The following is a description of a gene set: species: Homo sapiens Germinal centers (GCs) are clusters of activated B cells built on stromal cells known as follicular dendritic cells (FDCs). In the Peyer’s patches (PPs), GCs are chronically induced by bacteria and are the major sites for generation of gut IgA immune responses. Whether FDCs directly contribute to the IgA production in PP GCs is unknown. To investigate the role FDCs in gut immune system, we examined comprehensive gene profiles of FDCs purified from PPs or perypheral lymph nodes (pLNs) with or without immunization. We also tried to reconstitute the PP FDC signature in vitro by pulsed or continuous stimulation of pLN FDCs through TLRs, RARs or simultaneously through TLRs and RARs. Human Gene Set: GSE19401_PAM2CSK4_VS_RETINOIC_ACID_AND_PAM2CSK4_STIM_FOLLICULAR_DC_UP Genes up-regulated in the in vitro follicular dendritic cells from peripheral lymph nodes (96h): Pam2CSK4 versus tretinoin and Pam2CSK4. from publication Suzuki K, Maruya M, Kawamoto S, Sitnik K, Kitamura H, Agace WW, Fagarasan S (PMID 20643338), and this is the list of marker genes: RPL36A, CYP2A7P1, AK4, MPC2, CCDC71, PPP1R10, RRAGD (NCBI Gene Id 58528), PDK2, TRIM25, CYP46A1, CYLC2, DNM1, LAX1, VWA7, POMC, PRDX1, VPREB1, GCNT4, OSTF1, KCNK10, TRIP11, DIPK1A, SELENOT, ELAVL4, MN1, DNAI1, SHC3, EEF1D, SAA3P, CMC4, NDUFB11, CANX, SUV39H1, DUSP21, NGFR, TCTN3, PTH2R, OTUB1, ASB6, FAM117A, SOS1, P3H1, PSMG2, GADD45G, ZGPAT, GAP43, ZNF669, KLHL29, OSGIN1, SLC35B1, ZFY, ZNF771, CRNKL1, CORO1C, ELL, FCER2, GATA4, FUT8, NFKBIB, MAD2L1BP (NCBI Gene Id 9587), USP2, OLR1, CHRNA6, MAGEB2, C1QA, H4C1, PPRC1, SIGLEC6, PORCN (porcupine O-acyltransferase), LINC00623, CATSPERB, GLRA1, RAB4A, VARS1, FEZ1, DYNC2I1, CSNK1G3, DDX19A, MYOZ2, CLBA1, DDX11, SLC27A3, HMGCL, C1R, DTX3, PRPSAP1, PUS7, ZNHIT3, TMED2, SLA, MGAT5, TYR, CEACAM3, KDELR2, RNF141, SLC20A2, CASP9, PTPRJ, PIGL, FBXL6, NPAS2, RASA1, CTNNA2, SPINK2, PIM2, GPN2, COPE, TDO2, ABCA1, INPP5J, DIXDC1, SLCO3A1, FKBP1A, SEC14L5, RPS10, S1PR1, SEC23IP, PSMC3, OLFML1, ASGR1, AP3S1, RBP3, ZZZ3, SLIT3, RBM23, GLI2, BRWD1, POU4F2, PNPLA6, MICAL2, HSP90AB1, CEMP1, AMFR, THNSL2, ECE2, MRPS30, RAB32, P2RY11, LBH, SH2D2A, KRT6A, PSMB4, SAFB, ANKS1B, RER1, MYBPH, RBM7, C21orf91, AATF, TRPC2, ZFPL1, NAGK, PLPP1, STAG3, KIT, GOLGA1, DLC1, HHLA2, SIRT1, SCLY, CALM3, TSPAN3, SRY, GALR1, NDUFC2, BCL11A, PLXNB1, H2BC4, KRT32, GPR27, TSSK1B, CENPM, GCNT2, LHX3, WDR45B, OR3A1, DHPS, RPN1, LMTK2, DDT, SCGB1A1 (NCBI Gene Id 7356), CHRNG, TOP3A, SCAP, NRL, RHBDD3, SH2B1, SFTPA2, USP21, LST1, GSTZ1, MPP1, PMS2P5, CAAP1, CYP1A1, MOBP, ZC3H13, SPSB1